Given this list of marker genes MCUR1, ROMO1, CNN2, XDH, CD27, SCGB1A1, ATF6, SEPTIN7, COL2A1, ENO3, GBP4, MYH11, NMI, LUC7L2, JAK3, MYH14, IER2, RNFT1, LEF1, IRF5, ADK, DYNLL1, POU2AF1, BASP1, LPCAT3 (lysophosphatidylcholine acyltransferase 3), HTR1A, GLYR1, CYP1A1, KLHDC2, ST13, VAMP5, ZNHIT1, NDFIP1, KCTD12, GLI3, GNG4, ID3, RNF19A, ADGRD1, RTN1 (reticulon 1), MDFIC, UTP4, USF1, IRF9 (NCBI Gene Id 10379), TSR1, HSPA4L, ZFP36, MRPS18B, CD5L, CD28, CENPV, COL7A1 (collagen type VII alpha 1 chain), AKR7A2, ITIH5, FGL2, PFKP, LRP10, GNAI3, INHBA, PRKCH, GZMB, PLD3 (phospholipase D family member 3), DUSP2, SNX12, RGS2, RETREG1, RAMP3, STAT6, IFI35, HIF1A, CPNE6, AP1S2, LARP7, CYP51A1, EIF3C, PTGFR, CYTIP, GNPNAT1, PRKCA, PRKACA, GBA1, DIO2, EGR1, GM2A, B4GALNT1, PTGES, SCEL, EPHX1, CMIP, COMMD7, ERF (ETS2 repressor factor), TRAPPC4, ZFP36L2, ZNF362, CD9, DIPK2A, NFATC1, TWIST2, IL3RA, SRC, POLR1A, STK25, CLIP2, LPIN2, PITPNC1, PSMB10, CRTAP, ITM2A, HDAC1, SH2B3 (SH2B adaptor protein 3), MAPKAPK2, PSMB8, SH3BP2, AQP4, SHISA5, USP38, TLE3, KCNB1, TRAFD1, ILF3, TMEM126A, AEBP1, ELP3, MAPK6, HMCES, DDX19A, PSME1, WDR43, HRK, PDCD1, UNC5C, PTPN1, DNAJA1, NR4A2 (NCBI Gene Id 4929), TENT5C, ST6GALNAC4, SEMA6A (NCBI Gene Id 57556), NFKB1, BABAM2, CD53, PAK2, ATG4B, HLA-B, RRP1B, MFAP2, NSMF, CCT6B, RAD9A, GBP2, CXorf38 (chromosome X open reading frame 38), PSMB9, PITPNM1, GUCY2D, TMC6, RAP1GDS1, SNX21, GUSB, SETD6, POLD4, HINT2, CRX, FGFR3, NAB1, NRTN, FUS, LITAF, SPCS2, RGS3, SERPINB9, GAST, CLGN, LONP2, C5orf15, SSTR2, SAA2, COMT, TRIM59, KCNK4, PRR13, IDI1, LANCL1, ITGA7, IRF1, TSPAN5, SLC35G6, C1GALT1C1, SPTBN1, TAPBP, EGR2, NRGN (neurogranin), LCP1, MAPRE2, PRDX5, NR4A1, RPS6KA1, RHOG (NCBI Gene Id 391), HSPH1, PERP, NAB2, ADAM7, here is a description of the gene set: Genes down-regulated in comparison of control CD4 CD8 thymocytes versus those after stimulation with anti-Vbeta5 antibodies. from publication Niederberger N, Buehler LK, Ampudia J, Gascoigne NR (PMID 15661827) Comparison of gene expression changes in CD4+CD8+ thymocytes following engagement of TCR with anti-Valpha or Vbeta antibodies species: Homo sapiens Human Gene Set: GSE1448_CTRL_VS_ANTI_VBETA5_DP_THYMOCYTE_DN